Given this list of marker genes Foxp3, Blm, Ripk2, Il1b, Il1a, Bmi1, Shh, here is a description of the gene set: Mouse Gene Set: GOBP_POSITIVE_REGULATION_OF_IMMATURE_T_CELL_PROLIFERATION Any process that activates or increases the frequency, rate or extent of immature T cell proliferation. species: Mus musculus